Given this list of marker genes DAPL1, S1PR1, LIF, XDH, MROH1, LY75, PATJ, FAM43A, ITGA4, PHYHD1, NT5E, TP63, TTC39B, C5, SNTB2, SDCBP2, ST14, RIPOR2, NRP1, EVI2B, ATP8B4, RRM2B, SDC4, GIMAP5, ANKH, SHCBP1L, ALS2CL, CDIPT, KHK, UPB1, DNAH8, MX2, HAVCR1, RFLNB, PRG4, CCDC88C, IER5, TF, ACSBG1, CYP4V2, DPH5, AHNAK, CORO2A, CYTH4, TBX21, HPSE, SLC35A3, SPN, BPNT1 (NCBI Gene Id 10380), AIM2, ADAMTS20, CDH1, NIBAN1, IGFBP4, IFI44, STAT4, FCGR2A, MAN1C1 (NCBI Gene Id 57134), CYBB, IL18R1, GALNT9, ZNF536, SLAMF6, MS4A6A, CCDC102A, HOPX, IFITM10, TENT5C, ABTB3, ARSB, NXT2, HVCN1, GM2A, SLC66A3, KLHDC1, ADGRG5, MAF, IFNGR1, NCF4, RHOB, SLC17A9, KMT2A, TLR1, AP1G2, F2RL1, IFNG (NCBI Gene Id 3458), SKAP2, MPEG1, DAAM1, MCTP2, SNX10 (sorting nexin 10), SUCLG2, CLEC10A, APP, AGAP2, S1PR4, ITGA6, RIN2, KCNN2, IFIT1, IL17RA, NCMAP, DSE, TK2, PEA15, LY86, DIPK1A, ADGRE5, RHOQ, RASA3, CCR2, FGL2, NOD1, TASP1, IPCEF1, SLC41A2, VDR, CTSH, RAB21, GRN, CLCF1, TMEM150B, GUCD1, DPP4, ZBTB16, IFIT3, PLEK, B4GALNT4, AQP3, SIDT1, SOCS3, CD68, HHEX, CASP1, IRF8, PNPLA7, IBA57, LDLRAP1, ITGAE, KLHDC2, ADCY7, FAM78A (family with sequence similarity 78 member A), AMIGO2, RNF144A, MPP4, TENT5A, DAND5, SMPDL3A, LAIR1, GABRR2, SYNE2, N4BP2L1, GOLM1, MAP3K5 (NCBI Gene Id 4217), CXCR3, TAP1, ZBTB25, HIBADH, CREBL2, OAS1, SCFD1 (NCBI Gene Id 51681), FAM167A, TJP2, GEM, TTC39C, MADD, CCND1, ATP10D, PPM1J, APPL2, CRLF3, DNAJB13, EHBP1L1 (EH domain binding protein 1 like 1), IL2RB, PDE3B, CD38, TMEM71, CTSS, PPP3CC, SGK1, GNA15, NTRK3, RNF32, CYB561A3, SELPLG, TRAF5 (TNF receptor associated factor 5), ENDOD1, TASL, ACADL, HS3ST3B1, ST8SIA6, TVP23B, COX6A2, HLA-B, KLF3, PDLIM4, DAXX, GPR68, C19orf12, TRPM6, here is a description of the gene set: studied in species Homo sapiens from publication Teng F, Zhou Y, Jin R, Chen Y, Pei X, Liu Y, Dong J, Wang W, Pang X, Qian X, Chen WF, Zhang Y, Ge Q (PMID 22022412) Genes down-regulated in comparison of SP2 thymocytes versus SP4 thymocytes. Human Gene Set: GSE30083_SP2_VS_SP4_THYMOCYTE_DN After positive selection in the thymus, the newly generated single positive (SP) thymocytes are phenotypically and functionally immature and undergo apoptosis upon antigen stimulation. In the thymic medullary microenvironment, SP cells progressively acquire immunocompetence. Negative selection to remove autoreactive T cells also occur at this stage. We have defined four subsets of CD4 SP, namely, SP1, SP2, SP3, and SP4 that follow a functional maturation program and a sequential emergence during mouse ontogeny.We used microarray to detail the global programm of gene expression during the maturation of murine CD4 single positive thymocytes